Given this list of marker genes ARHGAP6, CCR7, DGKG, CSRP3 (cysteine and glycine rich protein 3), MIR133A1, PRKCH, PLCD1, CCL19, DGKH, EDN1, CCL21, ANKRD1, DGKD, here is a description of the gene set: species: Homo sapiens An intracellular signaling cassette that starts with activation of phospholipase C (PLC) activity and ends with the activation of protein kinase C (PKC). PLC produces inositol 1,4,5-trisphosphate (IP3) and diacylglycerol (DAG). IP3 regulates the opening of calcium channels in intracellular calcium store, leading to the release of calcium into the cytosol. Calcium and DAG activate protein kinase C (PKC), which in turn activates downstream effectors. This cassette is often part of the phospholipase C-activating G protein-coupled receptor signaling pathway. Human Gene Set: GOBP_PHOSPHOLIPASE_C_PROTEIN_KINASE_C_SIGNAL_TRANSDUCTION